The following is a description of a gene set: Triggering of B cell receptors (BCR) induces a massive synthesis of NFATc1 in splenic B cells. By inactivating the Nfatc1 gene and re-expressing NFATc1 we show that NFATc1 levels are critical for the survival of splenic B cells upon BCR stimulation. NFATc1 ablation led to decreased BCR-induced Ca++ flux and proliferation of splenic B cells, increased apoptosis and suppressed germinal centre formation and immunoglobulin class switch by T cell-independent antigens. By controlling IL-10 synthesis in B cells, NFATc1 supported the proliferation and IL-2 synthesis of T cells in vitro and appeared to contribute to the mild clinical course of Experimental Autoimmune Encephalomyelitis in mice bearing NFATc1-/- B cells. These data indicate NFATc1 as a key factor controlling B cell function. Human Gene Set: GSE21063_3H_VS_16H_ANTI_IGM_STIM_NFATC1_KOBCELL_DN studied in species Homo sapiens from publication Bhattacharyya S, Deb J, Patra AK, Thuy Pham DA, Chen W, Vaeth M, Berberich-Siebelt F, Klein-Hessling S, Lamperti ED, Reifenberg K, Jellusova J, Schweizer A, Nitschke L, Leich E, Rosenwald A, Brunner C, Engelmann S, Bommhardt U, Avots A, Müller MR, Kondo E, Serfling E (PMID 21464221) Genes down-regulated in B lymphocytes with NFATC1 knockout stimulated by anti-IgM: 3h versus 16h., and this is the list of marker genes: CERK, SLA, FEN1, HEXD, NPEPL1, SNRNP25, CENPH, ADH4, RTEL1, ZNF286A, FZD7, NHP2, ZNF689, TEC, SLC7A1, AARD, HSPA2, HSPB6, CNR1, XYLT2, PRELID3B, CISD1, HJURP, PCLAF, PPP1R14C (protein phosphatase 1 regulatory inhibitor subunit 14C), AAGAB, SMC2, RPL14, GORASP2, SLC9A5, RAB2A, PREB, HDGF, NMRAL1, ELP4, UBR7, ZFP28, UFL1, ZC3H7A, ARHGAP11A, UHRF2, SSNA1, TAF11, ARL13A, SF3B3, ANKLE1, TPX2, TFAP4, CDKN3, CDCA3, RPL23A, TNC (tenascin C), INTS3 (NCBI Gene Id 65123), SEPSECS, SERP1, NDUFS8, TNFRSF1A, CERS6, RRP9, MIF, RPUSD4, AJUBA, TNFRSF25, CPSF3, BORCS5, RC3H1, GPR108, DBP, KCNK6, UQCRQ, FRMPD3, MKI67, LEPROTL1, VPS16, KIF14, SNN, CAMK1D, SRP68, KNTC1, EIF3C, XRCC6, PTPRA, BUB1B, MMS22L, CHCHD7, SAMD8, ALG8, CKAP2, ADAM19, GRK2, GPR132, CDIN1, LUM, PTPN18, RPRD2, POLE, GTF2IRD1, TNFSF14, NDC80 (NCBI Gene Id 10403), PCBP2, UBE2C, NEK2, PAOX, INAFM1, ARPC5L, NADSYN1, RACGAP1, NUDT3, PCCA, PPM1K, MAP4K1, BORA, PLEKHO1, DBF4, DVL1, PTBP2, LRRC75B, KDM8, FIRRM, MLST8, TBC1D31, MYCN, AURKA, CCDC63, IPO11, SENP6, URI1, GFM1, RBBP5, P2RX7, AVPI1, BCL9L, TDP2, ASB3, STAG2, HS6ST1, IPO5, H2AZ1, HUS1, NXT1, STARD3, WDR62, CDC20, MRPS5, ANLN, NUP35, RSF1, IPO7, POC5, ARID2, DDRGK1, CRYGN, LRP8, MNS1, FAM110A, HAUS3, SNX10, SIX6, CTH, ARL2, NAP1L1, EIF3B, ATL2, PPM1F, ATG16L2, CNIH1, SGO1, PNPLA2, DCAF8, TRIO, PRC1, MARVELD1, PLEKHF1, HAUS7, TMEM14C, GPR183, NUP205, SF3A1, DHX29, NMT1, USP36, SRSF11, VRK1 (NCBI Gene Id 7443), ASF1A, BET1, CKAP2L, FKTN, HIRIP3, IL31RA, KMT5C, RPA3, SMC1A, ZCCHC8, CLIP1, FBXL6, E2F2, GFUS (GDP-L-fucose synthase), ACBD3, CCDC117, TGIF1